The following is a description of a gene set: Genes down-regulated in comparison of B cells from LAIV influenza vaccinee at day 7 post-vaccination versus those from TIV influenza vaccinee at day 7 post-vaccination. Systems vaccinology has emerged as an interdisciplinary field that combines systems wide measurements and network and predictive modeling applied to vaccinology. Here we used the systems vaccinology approach to study the molecular mechanisms underlying th species: Homo sapiens from publication Nakaya HI, Wrammert J, Lee EK, Racioppi L, Marie-Kunze S, Haining WN, Means AR, Kasturi SP, Khan N, Li GM, McCausland M, Kanchan V, Kokko KE, Li S, Elbein R, Mehta AK, Aderem A, Subbarao K, Ahmed R, Pulendran B (PMID 21743478) Human Gene Set: GSE29618_LAIV_VS_TIV_FLU_VACCINE_DAY7_BCELL_DN, and this is the list of marker genes: RPRD2, TMSB10, TENT5A, ROGDI, MAGI2, SCFD1, FIP1L1 (factor interacting with PAPOLA and CPSF1), EIF4E2, TMEM260, KCNQ1, RPL32, IRF3, CCDC9, MKRN2, RPLP2, NLRP1, IPO9, CTNNA1, DPEP1, MGLL, PALS1, DHX40, GYG1, LSM2, RPGR, SULT1A2, CORO1A, ELL2, COX7C, RPS20, WDR47 (NCBI Gene Id 22911), TMEM39B, FAM3A, RGS10, COPS3, FKBP15, KPNA6, ARIH1, CGRRF1, SMYD5, BANF1, YES1, FARSA, R3HDM1, PIAS3, CCNB1IP1, SPAG7, CAPRIN1, FAM131A, NRBP1, ANXA7, RPL23AP53, SLC15A3, TUFM, SP2, CCDC92, VCP, BPHL, WNT1, SETD3, RPS6KA4, HERC6, EIPR1, TLE4, NCOA1, TBC1D8, TRIM21, C11orf24, ATP5MJ, COBLL1 (cordon-bleu WH2 repeat protein like 1), FYN, MAPK14, IRAK1, RNF115, RPS24, RIPK1, FAHD2A, RAF1, DPEP3, RORA, MYCBP, PLAA, RAB6A, H2AC18, SMYD2, H2AC8, DRG2, STX17, TSG101, ICE1, RCN1, NFE2L2, HLA-G, ZDHHC11, FBXO38, RPL30, RALY, CD2BP2, NDUFB4, LPCAT3, SERF2, ERCC1, PIK3CB, UQCR10, TASOR, EIF3H, PRSS53, DGUOK, CDK6 (cyclin dependent kinase 6), MMP24, AHR, RPS26, MRPS15, RBPJ, VAMP3, HK2, GNG5, MAPKAP1, LGALSL, GNAI2, RPL6 (ribosomal protein L6, NCBI Gene Id 6128), ARFGAP2, EBAG9, CEACAM7, HHAT, OGFOD2, ESR2, PPP2R5A, BAG6, PFDN1, KDELR1, PSMG2, STX4, PARP11, ENPP4, GABBR1, MBD1, ATP1B3, ACYP2, RPL37, PEX13, GUK1, CCDC86, TMBIM4, SDHD, VIPR1, ZBTB40, BRCC3, SLC7A7, LGALS8, MID1IP1, DYNLT3, MT2A, NR3C1, ZNF207, ZNF267, FUT2, ATOX1, ITFG1, APRT, C2CD2, RPL31, CAPZA2, ENTR1, MRPL41, RBM23, MFF, YARS1, CITED2, CAPN2, TTI2, YWHAH, TBL1X, RPL7A, EMC3, SUCLA2 (succinate-CoA ligase ADP-forming subunit beta), RCN2, WDR45B, RIPK2, CDKL2, GLB1 (galactosidase beta 1), ACVR2A, USP3, NXT2, CAMKV, CDK2AP2, BLOC1S1, BCL3, RPS27, ARFIP2, MEIS3P1, SLC12A7, HDAC4, H1-4, RPS25, NUDT9, MBNL2, NELFCD